Given this list of marker genes UBE3C, CNKSR2, ATP5F1C, SCG5, SRP19, NPTN, AUH, OMG, SNX17, HSP90AA1, OPTN, DDHD2, CREG1, DDOST, GNAS, TAC1, NREP, NELL2 (NCBI Gene Id 4753), RGS4, AHCY, GLRB, CHN1, TAX1BP1, TTC3, TDP2, CD200, NCKAP1, OPCML, ATP2B1, RAN, VIPR1, SHOC2, SC5D, ME3, CRHBP, POLR2E, RTN4, KARS1, RNF44, UBE2A, UBA1, PRKAR1A, DGKB, CIRBP, MOAP1, MAP2K1, YME1L1, RYR2 (NCBI Gene Id 6262), PFN2, MAPK9, NRXN1, C1QBP, SARAF, PFKP, CERS6 (ceramide synthase 6), ELMO1, COPG2IT1, PSMD7, ZNF365, MGST3, H2AZ1, PPM1H, PPP2R2A, SERINC1, SEC23A, FAM168B, HSPA13, CANX, RGS7, DYNC1I1, ABHD14A, HPRT1, RER1, RTN1, RNF4 (NCBI Gene Id 6047), DYNC1H1, ATP6V1B2, FAM32A, EPHB6, ATP6V1C1 (ATPase H+ transporting V1 subunit C1), KIFBP (NCBI Gene Id 96724), KIF3C, DNAJA2, KDM1A, ZNHIT3, ZC3H15, PRPF8, LDB2, PPID, PSMB6, PHF24, YWHAQ, NRIP1, COX7A2, STXBP1, RTCB, UQCRC2, ACTR1A, DPY19L2P2, RAPGEF5, DOCK4, NELL1, NMNAT2, TMEM158, KALRN, MOB4, HPCA, ARF1, PSMD1, CACNA1A, DUSP8, AHSA1, KCNF1 (NCBI Gene Id 9036), PREPL, INPP5F, NDUFS2, MAP2K4, FOXG1, RIT2, SNU13, SST, NDRG4, SKP1 (S-phase kinase associated protein 1), UBE2N, CAP2, AKT1, STX4, MDH1, UBE2E3, ADAR, ADAM23, EID1, KCNK1, CSRNP2, KLC1, IDI1, CDK5, REEP1, GNAI1, NDUFA5, TCEAL1, TECR, CAMK1G, ARPC1A, STAU2, AASDHPPT, STX1A (syntaxin 1A), TSR2, CAMK2G, BRINP1, PPP2R1A, PSMA4, CALB1, HTR2A, ATP6V1E1, DUSP14, GDE1, EGR3, INA, NEFL, SNCB, MAPK1, VDAC1, RUNDC3A, ALDOA, EHBP1, PEX19, RNF11, STIP1 (NCBI Gene Id 10963), TUBB2A, SLC25A36, RAB1A, SNRPB, EPS15, HSP90B1, SCHIP1, KIAA0513, GRINA, TKT, ASNS, CEP170, SNAP25, CRMP1, ATP5MC3, GGCT, AHNAK2, COX8A, PCDH8, RAB11A, SLC9A6, LANCL1, OXA1L, MADD (MAP kinase activating death domain), TOGARAM1, SDF2, PDHB, PGK1, DOCK3, BHLHE40, ACOT7, HNRNPK, COX7A2L, ZFAND5, TSNAX, GABRA5 (NCBI Gene Id 727729), SCRN1, CCK, DRG1, SYNGR3, NPTX1, DOC2A, SYT17, PDE2A, ATP6V1D, ISCU, XPO7 (exportin 7), RSRC2, YARS1, NCALD, TM9SF4, USO1, PRUNE2, ERP29, CHGA, NSF, SERINC3 (NCBI Gene Id 10955), RNF13, SCAMP1, FIBP, WSB2, AKAP11, ATXN10, SEC24B, ABR, UBB, PLD3, RTF1, ZBTB18, SLC25A4, NDUFS3, PSMD11, HYOU1, STX7, CLIP3, PSMA3, BAP1, NECAP1, USP14, FBXO9, CLTB, TIAM1, JOSD1, GOT2, SLC25A12, UQCRFS1, ANKRD46, ATP6V1A, PRKAR2B, NONO, DDX10 (DEAD-box helicase 10), PPP1R12A, C2CD5, PIP5K1C, PGRMC1, PDHX, CAMSAP2, RAD21, RASA1, TRIM23, EEF2, PAK1, CUL1, BLCAP, ASS1, KIF3B, MAN2A2, CYFIP2, PCSK1, FHL2, TBCC, COPS7A, ADGRB2, RALYL, HNRNPA3, SOCS5, MNT, ATRNL1, TSPYL4, AARS1, DNM1, CHL1, ARHGEF9, LDOC1, ATP6V1F, ABCF3, PAFAH1B1, UBA2, TMEM59, GABRD, PRKACB, SLC20A1, DCLK1, NDN, CYC1, SCAMP3, PFDN1, GPD1L, PRPS1, ACTR1B, YWHAB, PSMB4, MBNL1, NDUFV1, EIF4H, B4GALT6, G3BP2, PISD (NCBI Gene Id 29838), BRD2, CCT2, CACNG3, HNRNPR, TMX4 (NCBI Gene Id 56255), SUMO1, TRIB2, NPY, ATP6V0B, AREL1, HECTD4 (NCBI Gene Id 283450), SET, PSMD8, GARS1, SUMO2, KIAA0232, ABCC5, CLINT1, DLG3, EFNB3, TUBA4A, ADRM1, PRKCI, EIF2S1, SYT1, PEX11B, CALM2, FAM131A, SPINT2, ATP6V0C, NRGN, SLC17A7, PJA2, NCDN, GRIA2, ENSA, RNF103, PCMT1, TSPYL5, BNIP3 (NCBI Gene Id 664), SH3BP5, B3GALNT1, PRNP (NCBI Gene Id 96713), CAMK2B, SLC25A3, TOMM34, MLLT11, PSME3, ACTN1, DHCR24, PLK2, SLC30A9, NAPA, RUSC1, TUBB4B, TOMM20, NDEL1, PUM1, EIF4A2, ATP1B1, HSPA12A, PRSS3 (serine protease 3), CALM1, CX3CL1, APLP1, ALAS1, OAZ2, OAT, ITPR1, SUB1, LMO3, MAST3, ICAM5, BTBD3, RCN2, SERPINI1, TOB1, ATP6V0D1, PNMA2, PUM2 (pumilio RNA binding family member 2), GPM6A, MBTPS1, MARCKS, SYT11, FHL1, MAPT, ISCA1, SCG2, UBC, RFK, CETN2, TSPAN3, GMFB, PTK2B, PPP6C, MORF4L2, KLF10, OAZ1, DCTN1 (dynactin subunit 1), HINT1, RAB4B, WDR47, PSMC1, UBL3, SLC39A6, CTBP1, DNAJA1, PSMC6, DDX1, ANXA7, APLP2, ACTR2, OSBPL1A, KIFAP3, LRPPRC, COPS8, SLC25A11, CACNB3, AP2S1, PRPSAP1, PGAP4, TMED2, SLITRK5, MACROH2A1, SRSF2, GABRA1 (NCBI Gene Id 2554), PKM, MYCBP2, HMGCR, TUSC3, GOT1, C1orf216, ENO2, GNB1, LYRM9, VDAC3, ANXA6, PTPRN2, SERPINF1, AMPH, SLC12A5, OGA, RAD23B, MPC2, HSP90AB1, WDR7, TUBB3, KCNAB1, SYNJ1, RABAC1, CYRIA, PSMD12, ATIC, PINK1, ITM2A (integral membrane protein 2A), PPP1R7, NDUFAB1, PSAP, NFE2L1, ATP2A2, MIF, SPAG7, SARS1, GUCY1B1, IDH3B, NECAB2, GSTA4, REEP5, SUCLA2, TBC1D9, IDH3A, VDAC2, DCTN3, PWP1, GABRG2, STMN2, GPX4, C6orf62, VSNL1, HIVEP2, AKR1B1, RRAGA, MAP1LC3B, UBQLN2, COPS3 (COP9 signalosome subunit 3), DPP6, TRIM37, CHST10, RCAN2, GNB5, SNRNP40, PSMA6, NDUFS1, NNAT, SORL1, CAPZA2, HNRNPA0, EFR3A, CX3CR1, MTMR9 (NCBI Gene Id 83651), THY1, BTBD8, SLC6A15, MAGED1, ATP6V0A1, FBXL2, EIF5, SRPK2, CHGB (chromogranin B), GABBR2, HMCES, CLSTN1, CNIH1, ATP1A3, PPP1R16B (NCBI Gene Id 26051), ARPP19, DSTN, SCAF8, NARS1, GABRA2, KHDRBS3, CRYM, UCHL1, NSG2 (neuronal vesicle trafficking associated 2), BNIP3L, VAMP7, RTL8C, GRIN2A, DUSP3, BEX4, here is a description of the gene set: Human Gene Set: KIM_ALL_DISORDERS_CALB1_CORR_UP Genes whose expression significantly and positively correlated with the density of CALB1-positive GABAergic interneurons in the BA9 brain region across all subjects with psychiatric disorders. Cytoarchitectural abnormalities have been described in the prefrontal cortex of subjects with schizophrenia, bipolar disorder and depression. However, little is known about the gene expression profiles associated with these abnormalities. Genome-wide expression profiling technology provides an unbiased approach to identifying candidate genes and biological processes that may be associated with complex biological traits such as cytoarchitecture. In this study, we explored expression profiles associated with the abnormalities by using publicly available microarray metadata and cytoarchitectural data from post-mortem samples of the frontal cortex from 54 subjects (schizophrenia, n=14; bipolar disorder, n=13; depression, n=12 and controls n=15). Correlation analysis between genome-wide expression levels and cytoarchitectural traits revealed that genes were significantly correlated with a decrease in the number of perineuronal oligodendrocytes across all subjects. A total of genes were significantly correlated with a decrease in density of calbindin-positive interneurons across all subjects. Multiple biological processes including cellular metabolism, central nervous system development, cell motility and programmed cell death were significantly overrepresented in both correlated gene lists. These findings may provide novel insights into the molecular mechanisms that underlie the cytoarchitectural abnormalities of perineuronal oligodendrocytes and calbindin-containing GABAergic interneurons in the prefrontal cortex of the major psychiatric disorders. from publication Kim S, Webster MJ (PMID 18762803) studied in species Homo sapiens